The following is a description of a gene set: species: Mus musculus Reactome Pathway: Acyl chain remodelling of PC part of: Glycerophospholipid biosynthesis This event has been computationally inferred from an event that has been demonstrated in another species.<p>The inference is based on the homology mapping from PANTHER. Briefly, reactions for which all involved PhysicalEntities (in input, output and catalyst) have a mapped orthologue/paralogue (for complexes at least 75% of components must have a mapping) are inferred to the other species. electronically inferred by orthology from the curated human pathway, and this is the list of marker genes: Tmem86b, Pla2g5, Pla2g3, Pnpla8, Pla2g4d, Pla2g2d, Pla2g1b, Pla2g2e, Pla2g2f, Lpcat4, Pla2g2a, Pla2r1, Pla2g12a, Pla2g4f, Plbd1, Mboat2, Lpcat2, Pla2g6